The following is a description of a gene set: from publication Chen Y, Wang X (PMID 31504780) Genes predicted to be targets of miRBase v22 microRNA hsa-miR-6815-3p in miRDB v6.0 with MirTarget v4 prediction scores > 80 (high confidence targets). studied in species Homo sapiens Human Gene Set: MIR6815_3P, and this is the list of marker genes: HNRNPU, ARHGAP6, PID1, BCL11A, SMARCAD1, NCS1, PCYT1A, SCN3B, KCNC2, SHKBP1, MIER3, GPR26, PHLDB2, RAB3GAP2, FAM174A, ST8SIA3, MEF2C, ENO1, RALGAPB, CD44, SUPT3H, CDK19 (cyclin dependent kinase 19), STXBP5L, TMEM239, AMMECR1, PRUNE2 (prune homolog 2 with BCH domain), HMG20A, PIP4K2C, NLGN3, LCMT1, RBPJ, TFDP2, DENND5B, ARHGEF3, ASCC3, GFRA1, NEO1, GRIK3, GNAI3, LAMP2, ACSBG2, MOSMO, CYYR1, ZNF426, CORO2B, UBA2, CACNB4, TIAM1, TTC21A, SLK, USP15, FOXJ2, MTMR1, PITPNM2, FBXO42, CPLX1, DENND6A, ADIPOR2, USP13, TOR3A, CCDC93, STRBP, NAV2, AQP9, SHOC2, C2orf88, SH2D3C, TRMT44, SIX6, PPFIA1, COA5, ZNF322, ZNF589, SLC44A1, PELI1, NBN, DCUN1D3, ZFYVE28, PHTF2, UGT8, ZBTB20, ARHGEF4, HPS3, HTR4, CASP8, EFNA5, ZNF544, EPB41, SLC44A5, STK35, BCL6B, ARHGEF6, ATXN10, ZSCAN22, SELENOH, KIAA1143, SPCS2, CXCL12, POLR1E, PEA15, ZNF74, RLIM, SAR1A, KCNE4 (NCBI Gene Id 23704), CYB5A, SUCLG1, CC2D1A, HIPK3 (NCBI Gene Id 10114), RAPGEF6 (NCBI Gene Id 51735), FUT10, SLC5A7, RIMS2, CCDC82, FASTKD1, FYCO1, KEAP1, IGF2R, RBPMS, PEDS1, P4HA3, RAB31, ZDHHC7, LMNA, RHO, SYT3, RHOA, NFYB, TMEM138, GNG7, DZIP1, DMRT1, ZNF559-ZNF177, GLIPR1, PGM2, PLXNA2, CLVS2, ATP8A1, NFATC1, CREG1, ZMYND11 (NCBI Gene Id 10771), PCDH10, BCL11B, XIRP1, EIF3A, ENTPD7, SRSF3, PEAK1, SLA, RNF169, TMEM182, ZNF135, RNF17, EFNB2, USP42, SUFU, HIF1A, LATS1, LINC03042, GPR3, BMF (NCBI Gene Id 90427), EPS8, KIAA0232, CCSAP, SLC25A32, SNPH (syntaphilin), MTNAP1, ANK3, SNTA1, USP46, ZDHHC6 (NCBI Gene Id 64429), ZFAND4 (NCBI Gene Id 93550), ZNF248, ST8SIA2, TMTC1, TNIP1, CFAP47, KIAA1671, CYTH1, MAP3K11, LRRC39, HDDC2, ORC2, DCP1A, TAB1, MTURN, DPPA3, NCOA1, LRP11, SCN8A, MAPKBP1, ERBB3, DLG2, MAT2A, CADM3, ELK1, BMAL2, PTX3, SOCS3, ZSCAN2, LZTS1, RYBP, PPP1R12C, SMARCA2, ANAPC10